The following is a description of a gene set: studied in species Mus musculus Mouse Gene Set: REACTOME_FORMATION_OF_THE_EMBRYONIC_STEM_CELL_BAF_ESBAF_COMPLEX Formation of the embryonic stem cell BAF (esBAF) complex, and this is the list of marker genes: Smarcd3, Smarcc1, Smarcd1, Smarcc2, Smarce1, Arid1a, Bcl7b, Actl6a, Smarcd2, Actb, Ss18, Bcl7a, Bcl11b (B cell leukemia/lymphoma 11B), Smarcb1, Smarca4, Bcl11a, Bcl7c